Given this list of marker genes EDNRA, ARHGAP18, MCF2L, PLOD2, SERPINB1, CCL7, here is a description of the gene set: Human Gene Set: PARK_OSTEOBLAST_DIFFERENTIATION_BY_PHENYLAMIL_DN from publication Park KW, Waki H, Kim WK, Davies BS, Young SG, Parhami F, Tontonoz P (PMID 19433444) species: Mus musculus Stimulation of osteoblast differentiation from mesenchymal stem cells is a potential strategy for bone repair. Bone morphogenetic proteins (BMPs) that induce osteoblastic differentiation have been successfully used in humans to treat fractures. Here we outline a new approach to the stimulation of osteoblast differentiation using small molecules that stimulate BMP activity. We have identified the amiloride derivative phenamil as a stimulator of osteoblast differentiation and mineralization. Remarkably, phenamil acts cooperatively with BMPs to induce the expression of BMP target genes, osteogenic markers, and matrix mineralization in both mesenchymal stem cell lines and calvarial organ cultures. Transcriptional profiling of cells treated with phenamil led to the identification of tribbles homolog 3 (Trb3) as a mediator of its effects. Trb3 is induced by phenamil selectively in cells with osteoblastic potential. Both Trb3 and phenamil stabilize the expression of SMAD, the critical transcription factor in BMP signaling, by promoting the degradation of SMAD ubiquitin regulatory factor 1. Small interfering RNA-mediated knockdown of Trb3 blunts the effects of phenamil on BMP signaling and osteogenesis. Thus, phenamil induces osteogenic differentiation, at least in part, through Trb3-dependent promotion of BMP action. The synergistic use of small molecules such as phenamil along with BMPs may provide new strategies for the promotion of bone healing. Genes down-regulated in M2-10B4 cells (osteoblast) in response to phenylamil.